The following is a description of a gene set: species: Homo sapiens Human Gene Set: MIR548D_3P Genes predicted to be targets of miRBase v22 microRNA hsa-miR-548d-3p in miRDB v6.0 with MirTarget v4 prediction scores > 80 (high confidence targets). from publication Chen Y, Wang X (PMID 31504780), and this is the list of marker genes: RPS6KA6, PITPNM2, TTC28, ZNF566 (NCBI Gene Id 84924), PDE7A, ZMIZ1 (zinc finger MIZ-type containing 1), ITPRIPL2, VEZF1, PDS5A, TSPAN3, CSNK1G3, SH3RF1, ZBBX, AHSA2P, SPIN1, DND1, ARGLU1, IPO8, UNC5D, CAMTA1, ZBTB21, RAF1, HSPH1, BCL2L11, USP24, ARL6IP6, MAPK6, C2CD2 (C2 calcium dependent domain containing 2), GFPT1, YTHDF1, MAP3K3, PXDN, UBR5, WDR44 (NCBI Gene Id 54521), PIK3CA, STX16, BCL2L10, VSTM2A, PIK3R1, SEPTIN2 (NCBI Gene Id 4735), IL6, LANCL3, TET3, CACNA2D1, MEF2C, SHISAL1, SPTSSA, TMEM170B, KDM2A, ICAM5, MTMR4, WNK3, IDS (iduronate 2-sulfatase), GIGYF1, TNRC6B, TGFBR1, DMD, UTRN, YBX3, SETD7, ARAP2, SLC25A16, RORA, CCDC14, MARK1, SMIM10L1, IRX2, ELMOD2, PRMT3, SPATA31A1, MOSMO, USP38, UBE2D1, CNTLN, SMG7, CARF (NCBI Gene Id 95855), KLF11, PPP1R14B, MID1, SIDT2, MOB4 (MOB family member 4, phocein), CNOT6L, CMTM6, TMEM63B, TMPO, MAPK1, TMEM64, PARP11 (NCBI Gene Id 57197), AZIN1, ANKRA2, ZNF468, CASC3, ZNF830, RC3H1, LSM14A, ARX, TP53INP1 (NCBI Gene Id 94241), PLGRKT, MSI2, VGLL3, SYT16, PIK3R3, HOXB7, NEK1, ING3, BAG5, PDCD7, SETBP1, EMP2, MDM4, RGPD1, SOCS5, IL6R, RASD1, SELENOI, B3GALT2, CAMSAP2, ANKRD28, HDGFL2, TLL1 (NCBI Gene Id 7092), GABBR2, STIM2, NUFIP2, SOHLH2, PCDH20, TUT7, HECTD2, ZNF614, SPATA31A6, MYEF2, CXCL12, FYTTD1, MITF, NAA50, COLGALT2, SPRED1, CYRIB, B3GNT5 (UDP-GlcNAc:betaGal beta-1,3-N-acetylglucosaminyltransferase 5), LPGAT1, RBMS3, SMURF2, EREG, PITPNM3, ZNF248, YPEL5, BPTF, NABP1, SMC1A, PDCL3 (phosducin like 3), BTBD10 (BTB domain containing 10), HIPK2, PAN3, KCNJ2, NUP98, PDE1C, NPAS3, UBE2H, DTNA, GORAB, MGARP, EIF1AX, BACH2, BCOR, C18orf54, IKZF2 (IKAROS family zinc finger 2), ZMPSTE24, FAM76B, DIS3L2, PRDM4, SOX6, HDX, ARHGAP29, OTUD7B, DOCK10, CCZ1B, ANO5, STOX2, CCDC34, PHC3, LOXL2, AEBP2, CSNK1A1, AKAP10, LEPROTL1, C5orf24, PELI2, KIRREL1, MARCKSL1, HIF3A, STRN3, DUS4L, CREBBP, YWHAZ, LLGL2, ZFAND4, BBS9, ATP2A2, BROX, SCN9A, MFSD14B, DNAJB1, NOTCH2, EPC1, ZNF547, ZNF207, QTRT2, TMCC1, EGR3, FZD6, POLR1A, SASH1, COL1A1 (NCBI Gene Id 4970), RSPRY1, CLP1, DLG1, SUZ12, FKBP5, CCNC, TNFSF11, SEMA6D, MYBL1, ZFAND5, TUT4, ETF1, PAPOLG, NOL7, TSC22D2 (TSC22 domain family member 2), ZMYM3, HUS1, MFSD13A, RNF38 (ring finger protein 38), INVS, HOXD13, RMI1, ZNF148, ATL3, SGO2, UGCG, PTPRZ1, ZNF704, MAML3, INPP4A, BPNT2, RETSAT, DNAL4, PTPRK, DDX6, WNT5A, SMIM7, CPSF6, ANKS1A, PMS1, GMCL1, TMPRSS15, AGL, MBOAT2, CNOT9, HOOK3 (NCBI Gene Id 84376), UBN2, RNFT2, PSD3, NRIP1 (nuclear receptor interacting protein 1), MAPK8, LIN7C, LRRC58, ADISSP, LARP4, ERO1B, SRP54, MBTD1, HOXA5, NDUFA4 (NCBI Gene Id 4697), LETM2, ROR1, RBM27, PPP1R2, TBL1XR1, TRHDE, DNAJB4, GPC6, EDIL3, CRLS1, CIPC, TOX, HDAC8, CDK14, PRKAR2B, ZNF583, TOX3 (TOX high mobility group box family member 3), LAMTOR1, MCU, GRIA2, PI4K2B, DAG1, ADARB2, ANKRD13C, RSBN1, GPATCH2, ZNF800, RRAS2, CCND2, ATXN7L3, IQGAP2, UHRF1, CCZ1, STOML2, SFPQ, TAF9, ELOC, PANK1, ITPA, HOXD8, RUNDC3B, ROBO1, API5, OSGEP, MAGOHB, SLF2 (SMC5-SMC6 complex localization factor 2), DOCK6, SEMA4B, RB1CC1, KPNA4, VKORC1L1, RCC1L, SKIL, TAF7L, USP42, ERGIC2, YTHDF3, RB1, FAT1, AZIN2, ALK, FOSL2, SCAI, TDRP, STAC, TAOK1, GPD2, MTRF1L, SLC2A13, PITPNB, DCUN1D4, DNMT1, ABI2, MCM9, ADGRG2, MXD1, ABCC2, GTF3C4, MYLK, MEX3C, SNRK, STARD4, HELZ, SON, FOXN2, FANCC, CDK17, MFAP3L (NCBI Gene Id 9848), CD96, SLC35A3, RBL2, ATP2B2, SLC44A1, ERP44, TCF7L2, TMEM59, ALKBH1, MED13, SPATA31A5, ARID1A (AT-rich interaction domain 1A), GABPA, STXBP4, HYCC2, LRRC37B, CHUK, PRKCI, ABHD13, FZD3, KLHL15, GOLM2, CNOT7, CCNYL1, KRTAP2-4, ZBTB43, ZBTB34, RAPH1, FAM169A, GCFC2, RNPC3, KIAA0232, ENTPD7, MAFB, SPATA6, ETNK1, PPP2R1A, SLC25A44, DNAJB12, OTX2 (NCBI Gene Id 5015), PUM2, BARD1, PM20D2, VAV2 (vav guanine nucleotide exchange factor 2), SCG2, GSE1, SLC18B1, KMT2A (lysine methyltransferase 2A), TMC7, MBNL3, NCL, TSPAN9, RSRC1, GNA11, BMPR1A, SNX12, MED1, SOCS6, HNRNPR, PAG1, PLAGL2, BOLL, MMGT1, RBM46, NAMPT, SERBP1, TTC14 (tetratricopeptide repeat domain 14), PDSS2, L2HGDH, SSR1, SIAH2, RP2, DYRK2, NTF3, TFPI2, FIGNL1, DOCK9, CADM2, HSPE1-MOB4, HUWE1, RCAN2, KDM7A, PID1, PRR14L, ACVR1C, ZCCHC14, ELAVL1, INO80D, GABRG1, G2E3, USP49, SOS2, ATP6V0A2, SGCZ, SCYL2, GRPEL2, MAP3K7, ICE2, CPEB1, ZFP30, SMC1B, UHMK1, POU3F1, LRFN3, ERBIN, DDX5, B4GALT4, DCBLD2, DPY30, CD47, RETREG1, SAMD8, MLLT1, FLI1, ZNF875, NAALADL2, EIF4G2, RASA2, CPD, SAR1B, FHIP1A, XIAP, BRD3, CPNE8, TSLP, COL4A1, MYC, VCPIP1, CPEB2, GNAI3, ZC3H12C, SDK1, LRRC8C, CTXN2, SAP130, RBPJ, POLD3, SOAT1, ZNF529, SUPT3H, SLC30A7, ZNF648, PRMT1, PNISR, MAP3K5, ARL6IP5, ARFGEF3, COX15, KCTD12, FSD1L, TBX3, APH1A, CCDC71L, PELI1, DNMT3B (DNA methyltransferase 3 beta), FMNL2, SORCS1, SYT4, CSNK2B, DYRK1A, CA13, RPS6KA3, EFEMP1, ZBTB41, PIM1, GRIN3A, FBXW2, RICTOR, RBBP4, TLNRD1 (talin rod domain containing 1), TANK, RASEF, ONECUT2, CRY1, SBK1, WWC3 (NCBI Gene Id 55841), COPS2 (COP9 signalosome subunit 2), GPR63, HDAC4, CDS2, RBM20, KRAS, RABEP1, AFF2, PLPP2, ACBD5, CABLES2, N4BP2L2, HLCS, PTBP2, TRIM28, SNX18, DNAJA2, DNAJB11, EGLN1, SKI, SPATA31A3, DCLK1 (NCBI Gene Id 9201), STK24, PTBP3, NAV2, ZNF28, SLC10A4, HNRNPC, LRRTM4, LOXL1, ZDHHC21, TMEM128, ANO3, ZBTB8A, AGPAT1, PSIP1, ATP2B4, SYNCRIP, TCP11L2, KMT2C, AKT1, ATP13A3, CREBRF, MAP2K4, IGF2BP2, MLLT3, TBCA, AMFR, ATF7IP, MOB1B, GABRA4, WWP1, USP16, RIF1, IER3IP1, XPR1, TM2D3, MARCHF5, MPZ, CCDC68, KIN, SETD3, MCL1, ERI1, MATR3, SPATA31A7 (NCBI Gene Id 642629), PRKAA2, FKBP1A, TRMT9B, PPM1B, YBX1, LIN28B, ZBTB22, TMEM131, KIAA0408